The following is a description of a gene set: This event has been computationally inferred from an event that has been demonstrated in another species.<p>The inference is based on the homology mapping from PANTHER. Briefly, reactions for which all involved PhysicalEntities (in input, output and catalyst) have a mapped orthologue/paralogue (for complexes at least 75% of components must have a mapping) are inferred to the other species. Reactome Pathway: RHOH GTPase cycle studied in species Mus musculus part of: RHO GTPase cycle electronically inferred by orthology from the curated human pathway, and this is the list of marker genes: Uaca, Rhoh, Lamtor1, Arhgdig, Jup, Pak6, Cav1, Lck, Vcp, Pak4, Arhgdib, Nsfl1c, Vangl1, Csk, Tuba1b, Rab7